Given this list of marker genes Sgip1, Ap2m1, Ston2, Ap2a1 (adaptor-related protein complex 2, alpha 1 subunit), Slc18a3, Tyrp1, Btbd8, Ap2a2, Tbc1d5, Eps15, Ap2s1, Epn2, Ap2b1, Ston1, Snap91, here is a description of the gene set: species: Mus musculus Mouse Gene Set: GOCC_CLATHRIN_COATED_ENDOCYTIC_VESICLE_MEMBRANE The lipid bilayer surrounding a clathrin-coated endocytic vesicle.